The following is a description of a gene set: The change in form that occurs when an epithelial cell progresses from its initial formation to its mature state. Human Gene Set: GOBP_EPITHELIAL_CELL_MORPHOGENESIS studied in species Homo sapiens, and this is the list of marker genes: TNMD, HOXA13, ARHGEF26, GRHL2, CCDC88C, VSIG1, RILPL2, ID1, BCL11B, PKHD1, DACT2, NOTCH4, PALLD, SIPA1L3, COL18A1, CLIC4 (NCBI Gene Id 25932), ROCK1, EPB41L5, SPINT2, AMOTL2, MET, HEG1, ADAM7, RAB25, MAGI1, PECAM1, RILPL1, CLDN3, FRMD6, FLNB, ST14, AR, PLOD3, POF1B, CDH5, LUZP1, IHH, STC1, RAC1, FAT1